Given this list of marker genes SCN5A, SCN7A, SCN2B, ASIC2, SCN9A, PKD2, HCN2, HCN3, SCN11A, SCN3B, HCN4, SCN4A, SCN3A, SCN2A, SCN1A, NALCN, HCN1, TPCN2, SCN10A, SCN4B, SCN8A, TPCN1, here is a description of the gene set: Enables the transmembrane transfer of a sodium ion by a voltage-gated channel. A voltage-gated channel is a channel whose open state is dependent on the voltage across the membrane in which it is embedded. species: Homo sapiens Human Gene Set: GOMF_VOLTAGE_GATED_SODIUM_CHANNEL_ACTIVITY